Given this list of marker genes ALDH18A1, RHOA, P4HA2, PLOD1, PHGDH, UGP2, P3H3, SLC16A1, CD36, P4HA1, GLUD1, P3H4, PSPH, FGFR1, SLC2A1, PSAT1, UGDH, PGM1, SLC1A5, LPAR1, SERPINH1, LDHA, BMP1, PYCR1, ADAMTS2, GLS, GPI (glucose-6-phosphate isomerase), GCK, P4HA3, PLCG1, LOXL2, FGFR4, here is a description of the gene set: Human Gene Set: WP_METABOLIC_PATHWAYS_OF_FIBROBLASTS species: Homo sapiens Metabolic pathways of fibroblasts